Given this list of marker genes CLTA, LSR, APOB, SOAT2, NPC1, CLTC, CES3, SOAT1, AP2A1, AP2S1, AP2A2, NPC2, LDLR, PCSK9 (NCBI Gene Id 50983), LDLRAP1, AP2M1, AP2B1, NCEH1, LIPA, here is a description of the gene set: LDL clearance Human Gene Set: REACTOME_LDL_CLEARANCE studied in species Homo sapiens